Given this list of marker genes SHMT1 (serine hydroxymethyltransferase 1), DTYMK, HS3ST1, CENPL, MS4A1, AGPAT5, MIPEP, CAD, ASF1B, KPNA2, SGO2, NUSAP1, SCD, LANCL2, H2AX, SPCS1, MCM3, TUBB (NCBI Gene Id 95295), PRR11, HROB, PSMB10, PSRC1, TBC1D7, GAR1 (NCBI Gene Id 54433), CCNA2 (cyclin A2), PYCARD, NME1, ZNHIT1, AP1S3, CCT5, ARHGAP11A, DEPDC1B, RAD54B, STARD4, SRL (NCBI Gene Id 6345), SLC39A14, ZMYND19, OLA1, ASH2L, ANP32E, AHSA1, RPA3, RIPK3, RAB35, LSM3, TTC7B, CSNK2B, MTFR2, KIF23, RECQL4, CHD7, VAC14, CMSS1, KIF2C, NUP62, RFC4, GINS2, RAN, SLBP, TUBG1, APMAP, FFAR2, CHCHD1, CHCHD4 (NCBI Gene Id 152281), SHCBP1, MRTO4, STIL, PSMC3IP, ARHGAP19 (NCBI Gene Id 84986), MCM5, CTNNBL1, SKA2, LMNB2, SPCS3, LRRC59, CDCA3, MYBBP1A, C2orf81, RBM14, TXN2, WARS1, NXPH3, NCAPH, MARS1, MRPL3, RARS2, NEIL3, SGSM3, CENPW, IQGAP3, GPATCH4, PIMREG, RFC5, CBY1, DDX39A, NOXRED1, C7orf50, PMF1, NOP56, TM2D2, GALNS, GMPPB, BCL2L1, NUP43, CDC20, RCL1, BEND3, MTHFD2, GNL3, C1QBP, CDK4, SKA1, BRCA1, RUVBL1, HK2, SERPINB1, MNAT1 (MNAT1 component of CDK activating kinase), PDK3, TSSK3, CDC45, TMIE, CTPS1, NKG7, NHP2, DHFR, GSTZ1, NPHP1, PREP, HIRIP3, SNRPB2, BOLA3, APOO, CCND2, FERRY3, HMBS, MRPL27, NAF1, CNDP2 (NCBI Gene Id 55748), PRIM1, CMC2, SRBD1, SNRPA, TEDC1, KMT5A, TCP1, ADAT3, GTF3A, FBXO5, FANCA, SLC39A11, WDR43, KNL1 (kinetochore scaffold 1), MKI67, SNX15, RAD51, ASPM, TBRG4, PRKCSH, STAP1, SF3A3, POLR3K, PARVG, TYMS, NUBPL, PUM3, SLC43A3, GCSH, ST3GAL6, NSL1, ADAT2, RRP8, SEPTIN11, RBBP8, GAS2L3, EIF2B1, NIFK, TUBE1, JPT2, NOC4L, EIF3L, TSR1, CCNB2, TRIP13, DNAJC24, PIM2, DNA2, PLAC8, NCAPD2, POLR2M, MRPL42, SHMT2, POLE2, TPST1, DKC1, ECT2, KIF18B, PLEK, PASK, RRP12, UTP14A (UTP14A small subunit processome component), here is a description of the gene set: Human Gene Set: GSE5679_CTRL_VS_RARA_AGONIST_AM580_TREATED_DC_UP from publication Szatmari I, Pap A, Rühl R, Ma JX, Illarionov PA, Besra GS, Rajnavolgyi E, Dezso B, Nagy L (PMID 16982809) Genes up-regulated in monocyte-derived dendritic cells: untreated versus AM580. species: Homo sapiens Our data indicated that activation of the PPARg nuclear receptor induces a retinoid response in human dendritic cells. In order to assess the contribution of retinoid signaling to the PPARg response we decided to use a combination of pharmacological activators and inhibitors of these pathways. Cells were treated with the synthetic PPARg ligand rosiglitazone (RSG), or with RSG along with the RARa antagonist (AGN193109) to block RARa mediated gene expression, or the RARa specific agonists (AM580) alone. This design allows one to determine if retinoid signaling is a downstream event of PPARg activation and what portion of PPARg regulated genes are regulated via induced retinoid signaling.